The following is a description of a gene set: Human Gene Set: GOBP_NEGATIVE_REGULATION_OF_PROTEIN_FOLDING species: Homo sapiens Any process that stops, prevents or reduces the frequency, rate or extent of protein folding., and this is the list of marker genes: PDCL3, BAG5, SNRNP70, METTL21A, PDCD5